The following is a description of a gene set: Genes changed in pre-B lymphoblastic leukemia cells with BCR-ABL1 fusion vs normal pre-B lymphocytes. from publication Klein F, Feldhahn N, Herzog S, Sprangers M, Mooster JL, Jumaa H, Müschen M (PMID 16205638) Pre-B lymphoblastic leukemia cells carrying a BCR-ABL1 gene rearrangement exhibit an undifferentiated phenotype. Comparing the genome-wide gene expression profiles of normal B-cell subsets and BCR-ABL1+ pre-B lymphoblastic leukemia cells by SAGE, the leukemia cells show loss of B lymphoid identity and aberrant expression of myeloid lineage-specific molecules. Consistent with this, BCR-ABL1+ pre-B lymphoblastic leukemia cells exhibit defective expression of IKAROS, a transcription factor needed for early lymphoid lineage commitment. As shown by inducible expression of BCR-ABL1 in human and murine B-cell precursor cell lines, BCR-ABL1 induces the expression of a dominant-negative IKAROS splice variant, termed IK6. Comparing matched leukemia sample pairs from patients before and during therapy with the BCR-ABL1 kinase inhibitor STI571 (Imatinib), inhibition of BCR-ABL1 partially corrected aberrant expression of IK6 and lineage infidelity of the leukemia cells. To elucidate the contribution of IK6 to lineage infidelity in BCR-ABL1+ cell lines, IK6 expression was silenced by RNA interference. Upon inhibition of IK6, BCR-ABL1+ leukemia cells partially restored B lymphoid lineage commitment. Therefore, we propose that BCR-ABL1 induces aberrant splicing of IKAROS, which interferes with lineage identity and differentiation of pre-B lymphoblastic leukemia cells. Human Gene Set: KLEIN_TARGETS_OF_BCR_ABL1_FUSION studied in species Homo sapiens, and this is the list of marker genes: SPIB, PTPRC, IL3RA, CD40, CSF3R, IKZF1, CD79A, NCF4, POU2F2, ANPEP, IGHMBP2, CBFA2T2, MNDA, CXCR4, CD33, EBF1, GATA1, PML, CSF1R, CD19 (CD19 molecule), POU2AF1, RAG1, TCF3, RUNX1, PAX5, MZF1, MPO, SIGLEC8, IRAK1, PROM1, SYK, MLF2, ITGAL, IRF4, MYD88, BTK, NUP98, GYPC, BLNK, RAG2, IGBP1, CD38, TNFRSF13B, DNTT, IL7R, SEPTIN9